Given this list of marker genes XCL1, AIRE, CCL20, ADAM8, CORO1A, CCR6, CCR2, here is a description of the gene set: The movement of a thymocyte through distinct intrathymic niches (e.g. medulla, cortex), where it receives a unique set of developmental cues required for T-cell development. species: Homo sapiens Human Gene Set: GOBP_THYMOCYTE_MIGRATION